The following is a description of a gene set: A form of programmed cell death that is accompanied by the formation of autophagosomes. Autophagic cell death is characterized by lack of chromatin condensation and massive vacuolization of the cytoplasm, with little or no uptake by phagocytic cells. species: Mus musculus Mouse Gene Set: GOBP_AUTOPHAGIC_CELL_DEATH, and this is the list of marker genes: Bnip3, Dapk1, Laptm5, Ctsl, Atp6v0c, Lamp1, Cdkn2d, Trem2, Atg5, Sh3glb1 (NCBI Gene Id 99782), Bmf, Cdkn1b, Trp53inp1, Acp2 (acid phosphatase 2, lysosomal)